The following is a description of a gene set: Human Gene Set: KEGG_MEDICUS_REFERENCE_CASR_PTH_SIGNALING_PATHWAY Pathway Definition from KEGG: Ca2+ -> CASR -> GNAQ -> PLCB -> IP3 -> Ca2+ -| PTH studied in species Homo sapiens CaSR-PTH signaling pathway. Pathway ID: N00291. Pathway type: Reference. Pathway class: nt06318 CaSR-PTH signaling., and this is the list of marker genes: PLCB1, PLCB4, PLCB2, PLCB3, GNAQ, PTH, CASR